Given this list of marker genes STRAP, H2BC13, ZBTB33, TFAP2A, HDAC2, TWIST1, SMARCA4, H2BC14, TGIF2, WT1, H2AX, PKM, H2BC5, SNAI2, H2BC26, H2BC4, SP1, H2AC20, MPHOSPH8, H2BC12L, H2BC9, H2AC14, RBBP7, KLF4, CDH1, FOXJ2, SNAI1, CTBP2, H2BC15, FOXA2, ARID1A, H2BC12, HDAC1, RBBP4, H3C1, KMT5A, ZNF217, CTBP1, H2AJ, EED, H2BC1, DNTTIP1, H2BC11, TWIST2, H3C15, SUZ12, H2BC3, TCF3 (transcription factor 3), KDM1A, FOXQ1, TLE1, TCF12, SIRT1, H2AC18, KLF9 (KLF transcription factor 9), H4C1, MAPK3 (NCBI Gene Id 5595), EZH2, H2AB1, H2BC17, H2AC4, RB1, H2AZ2, ZMYM2, ZEB1, MAPK1, H2AC7, H2BC21, ZEB2, H2AC6, FOXP2, H3-3A, MCRIP1, here is a description of the gene set: <p>Numerous transcription factors have been identified as direct positive regulators of CDH1 gene (also known as E-cadherin, epithelial cadherin, Cadherin-1, CADH1, or uvomorulin) transcription, including ARID1A, FOXA2, FOXJ2 (Martin de Lara et al. 2008; Zhang et al. 2018), KLF4, KLF9, RB1, SP1, and TFAP2A.</p><p>Downregulation of the CDH1 gene expression is one of the hallmarks of epithelial-to-mesenchymal transition, seen normally during development and wound healing, but also pathologically, during cancer progression. Expression of many negative regulators of the CDH1 gene is controlled by TGF-beta signaling, prostaglandin E(2) signaling, WNT signaling, and NFκB signaling. Well-established direct repressors of the CDH1 gene include SNAI1 (SNAIL), SNAI2 (SLUG), TWIST1, TWIST2, WT1, ZBTB33, ZEB1, ZEB2, and ZNF217.</p><p>Several splicing isoforms of CDH1 mRNA/protein exist and inclusion of some exons of CDH1 was shown to be regulated by the SWI/SNF complex.</p> species: Homo sapiens Reactome Pathway: Regulation of CDH1 Gene Transcription part of: Regulation of CDH1 Expression and Function